The following is a description of a gene set: species: Homo sapiens Evasion by RSV of host interferon responses Human Gene Set: REACTOME_EVASION_BY_RSV_OF_HOST_INTERFERON_RESPONSES, and this is the list of marker genes: UBB, RPS27A, UBC, IFNA7, UBA52, TRIM25, IFNA14, IFIH1, IFNAR1, IFNA2, EIF2AK2, IFNA8, CUL5, IFNA5, RIGI, MAVS, IRF3, IFNA1, EP300, IFNA13, IFNA16, STAT2, TYK2, RBX1, IFNAR2, IFNA10, IFNA17, IFNA21, CREBBP, ELOC, IFNB1, JAK1, IFNA6, ELOB, IFNA4